The following is a description of a gene set: To facilitate co-transcriptional capping, and thereby restrict the cap structure to RNAs made by RNA polymerase II, the capping enzymes bind directly to the RNA polymerase II. The C-terminal domain of the largest Pol II subunit contains several phosphorylation sites on its heptapeptide repeats. The capping enzyme guanylyltransferase and the methyltransferase bind specifically to CTD phosphorylated at Serine 5 within the CTD. Kinase subunit of TFIIH, Cdk7, catalyzes this phosphorylation event that occurs near the promoter. In addition, it has been shown that binding of capping enzyme to the Serine-5 phosphorylated CTD stimulates guanylyltransferase activity in vitro. species: Homo sapiens part of: RNA Polymerase II Transcription Reactome Pathway: RNA Pol II CTD phosphorylation and interaction with CE, and this is the list of marker genes: POLR2E, POLR2A, SUPT5H, POLR2C, GTF2H2, ERCC2, POLR2B, ERCC3, GTF2H1, CDK7, POLR2J, CCNH, MNAT1, POLR2I, POLR2F, RNMT, POLR2G, GTF2H5, POLR2K, GTF2F1, GTF2H3, RNGTT, GTF2H4, POLR2L, POLR2D, GTF2F2, POLR2H